The following is a description of a gene set: studied in species Homo sapiens Human Gene Set: GOBP_RHO_PROTEIN_SIGNAL_TRANSDUCTION An intracellular signaling cassette in which a small monomeric GTPase of the Rho subfamily relays a signal., and this is the list of marker genes: CELSR1, RHOG, CDC42SE1, PTH (NCBI Gene Id 5741), ARHGDIB, ARHGAP4, MIR21, ARHGAP5 (Rho GTPase activating protein 5), DLC1 (DLC1 Rho GTPase activating protein), TAGAP, DOCK8, CDC42EP5, PIN1, BCL6, RHOB (ras homolog family member B), CCR7, SCAI, SEMA4D, RASIP1, ARHGAP29, VANGL2, MCF2L, ARHGAP1, F2R, MYO9B, MYOC (NCBI Gene Id 4653), KCTD13 (NCBI Gene Id 253980), DOCK11, AKAP13, RHOA, PLEKHG5, ARHGEF11, DOCK9, CCL19, PLXNB1, NET1, TEK, COL3A1, CUL3, ROPN1B, RIPOR1, RHOJ, F2RL1, KCTD10, HEG1, ARHGEF28, RAF1, SRGAP1, EPS8L3, ARHGAP30, CSNK1A1 (NCBI Gene Id 55416), ITGB1, EPS8, CDC42SE2, ARHGEF3, SYNJ2BP, NRP1, ARHGEF2, RIPOR2 (RHO family interacting cell polarization regulator 2), PECAM1, ABCA1, ROCK1, PKP4, CTNNAL1, STARD13, ARHGAP6, RIT2, MIR223, AGTR1, STARD8, ARHGEF10 (Rho guanine nucleotide exchange factor 10), KANK1 (KN motif and ankyrin repeat domains 1), CDC42EP3, RAC1, FLCN, LRRK2, RTN4R, PHACTR4, MET, CDC42EP1, PRAG1, HACD3, C15orf62, TAX1BP3, LPAR1 (lysophosphatidic acid receptor 1), ARHGAP20, GNA12, RTKN, GPR4, FLOT1, BCR, RACGAP1, GPR55, ARHGAP42, OPHN1, PLEKHG7, ABL1, ADGRG1 (adhesion G protein-coupled receptor G1), CDH13, FXR1, DOCK10, STMN1, ABL2, ABRA, ARRB1 (arrestin beta 1), KANK2, WAS, ADRA2A, ARHGDIG (NCBI Gene Id 398), PDPN, DOCK6, CDC42EP4, RALBP1, ARHGAP27, SYNPO2L, ARHGEF16, CCDC125, ITGA3, CFL1, NGFR, ERBB2, EPS8L1, FERMT2, COL1A2, APOE, APOA1, ROBO1, ARHGEF1, ARHGAP35, DOCK7, ARHGEF12, NTN1, ARHGEF7, SHTN1, ARHGEF18, LPAR2, ROCK2, RHOD, ARHGDIA, EPS8L2, GNA13, APOC3, LIMK1, F11R, TNFAIP1, CDC42EP2, PDCD10